The following is a description of a gene set: species: Homo sapiens Genes predicted to be targets of miRBase v22 microRNA hsa-miR-4279 in miRDB v6.0 with MirTarget v4 prediction scores > 80 (high confidence targets). Human Gene Set: MIR4279 from publication Chen Y, Wang X (PMID 31504780), and this is the list of marker genes: AMER2, LYPD6, CAMK1D, ZSWIM5, NR6A1, MMD2, MSL1, SIRT5, MYO5A, RHD, ATXN1, GEMIN5, FAM234B, KMT2C, ETV1 (NCBI Gene Id 221810), USF3, ZNF33A, DCAF7, ANKRD6, NPR1, BAZ1A, ARSJ, SMPD3, STXBP5, CLASP2, DNAJB4, TTLL4, ARHGEF28, ERICH5, MCHR2, SSBP2, PELI2, EBLN2, ATP8A2, TMEM65, RIMS3, CNOT4, GSTCD, ZNF80, KLF3, HIPK1, DBT, GLI1, DYRK2, EZH1, BCOR, PRDM1, STAG2, FBXO45, CLOCK, TIFA (TRAF interacting protein with forkhead associated domain), ATMIN, KCNMA1, HDAC6, PELI1, SRF, NEXMIF, MARCHF1 (membrane associated ring-CH-type finger 1), ALG10B, SOX4, SMARCA1, KPNA6, DHRS12, TANC1, ADGRL3, SNX27, PCYOX1L, KPNB1, OXR1, LINC03103, FAM168A, ZNF551, SNX19, KCNN3, PRKAG2, INHBC, XPR1, OPA3, TMX3, CFAP65, SH3BGRL, KLHL15, CDK6 (cyclin dependent kinase 6), GREM1, FBXO32, ROR1, DYNC1LI1, RALGAPB, MPC2, GK5, ADCY6, EMCN, PAFAH1B2, CACNA1E, STXBP5L, SDHC, PDF, ANKRD13A, TFCP2, SELL, C11orf87, C1orf56, GLRA4, KCNB1 (potassium voltage-gated channel subfamily B member 1), MVB12B, P2RY10, OAZ1, DGKG, KCNH5, ATAD1, UBXN4, KSR2, GTF2F2, SH3TC2, RWDD1, GANAB, TARS2 (threonyl-tRNA synthetase 2, mitochondrial), DSE, HAPLN1, ANGPT4, STXBP3, PGPEP1, KDM2A, NRAS, STK35, CACNG8, INSR, STK3, MARCHF5 (NCBI Gene Id 54708), IRF2, ANKS6, CD274, TMEM276-ZFTRAF1, KIAA1958, PLXNA2, MGAT3, ZNF426, WBP2NL, MKRN1, NMD3, PWWP2A, YTHDF3, TCF21 (NCBI Gene Id 6943), PGAM4, NFASC, ITIH5, ARHGAP26, EMP2, MYRFL, DLX4 (distal-less homeobox 4), GPR62, CASK, SLC25A20, ADORA1, GDAP2, USP18, GNAL, SLFN13, CLIC5, GPR162, FGG (NCBI Gene Id 2266), BCL9, CLCN5, TSPYL1, PPTC7, CHMP7, THSD4, SH3KBP1, ZNF33B, PXN, ZNF202, CLCN3, ARID1A, C5orf63, LAMA1, TIPRL, GLCCI1, THY1, ZBTB43, TBC1D32, FOS, STON2, BMF, CTDSPL2, CPEB4, PRKAA2 (protein kinase AMP-activated catalytic subunit alpha 2), RPTN, SNX8 (NCBI Gene Id 29886), COL6A5, COG8, KCNK10, SSR3, POGLUT3, PRICKLE2, DOK6, TNRC6B, TCEA1, KLF12, GSTZ1, PDGFC, GFPT2, EPAS1, CTXN3, STON1-GTF2A1L, ZNF75A, HECA, USH2A, SLC1A2, CENPF, TLK2, OLFML2A, HIPK2, DEPP1, TSPAN7, CREBBP, NDST1, AFF1, ZNF793, TTLL2, TTYH2, TVP23C